The following is a description of a gene set: Human Gene Set: GOMF_DNA_REPLICATION_ORIGIN_BINDING species: Homo sapiens Binding to a DNA replication origin, a unique DNA sequence of a replicon at which DNA replication is initiated and proceeds bidirectionally or unidirectionally., and this is the list of marker genes: MCM2, KAT7, ORC3, POLA1, MCM5, DHX9, MCM10, HSPD1, ORC2, CDC6, ORC5, DDX11, CDC45, ORC1 (origin recognition complex subunit 1), ORC4, GRWD1